Given this list of marker genes Tspan5, Myorg, Zfp275, Zbtb5, Usp38, Intu, Hif1an, Hand1, Alox8, Nr6a1, Tbkbp1, Rasgrp1, Hmga2, Leprotl1, Crb2, Trabd, Prpf38b, Smug1 (NCBI Gene Id 97982), Tgds, Rgs16, Rab8b (RAB8B, member RAS oncogene family), Cbx2, Slc2a12, Pcdh19, Cpeb2, Slc25a24, Pik3ip1, Hip1 (huntingtin interacting protein 1), Fgf11, Slc25a27, Hoxa1, Pde12, Thoc2, Nme6, Zfp583, Pcdh20, Sestd1, Ppargc1b, Gpatch3, Prkaa2, Col27a1, Ccnj, Dtx2, Mapk8, Hic2 (NCBI Gene Id 58180), Nras, Pitpnm3, Wnt9a, Begain, Agap1, Cgnl1, Lpgat1, Gpr156, Diaph2, Coil, Fign, Plekho1, Soat2, Il13, Tmod2, Liph, Fam174a, Rab11fip4, Stard13, Tgfbr3, Klk10, Gcat, Slc38a9, Scn11a, Etnk2, Ttll4, Abcb9, Acvr1c, Rictor, Igf2bp2, Adrb3, Bsn, Gatm, Ybey, Galnt1, Styk1 (serine/threonine/tyrosine kinase 1), Cflar, Atp2a2, Cpa4, Scyl3, Eef2k, Arhgap12, Zswim5, Fam135a, Gabra6, Gng5, Plpp6, Mdfi, Fndc3a, Pard6b, Igdcc4, Slc6a1, Usp47, Dna2, Kdm3a, Cemip2, Kctd21, Ddx19a, Slc16a14, G6pc2 (NCBI Gene Id 14378), Tmco1, Ccnd2, B3gnt7, Nap1l1, Cep120 (centrosomal protein 120), Fasl, Ints6l, Sowaha, Lipt2, Mycn, Cry2, Nemp1, Efhd2, Fgd6, Limd2, Masp1, Cep135, Slc66a1, Pbx1, Zfyve26, Brd3, Rgs6, Stxbp5, 2310022A10Rik, Lbr, Snn, Macf1, Mapk6, Taf9b, Usp24, Lin28b, Igdcc3, Rufy3, Plxnc1, Acat1, Igf2bp1, Faxc, Entrep2, Snx30, Ccdc71l, Eea1, Klhl6, Map3k2, Brwd1, Homer2, Plpp5, Dusp1, Dlc1, Asap1, Arid3b, Nek3, 1700017B05Rik, 5031439G07Rik, Trim41, Tmem65, Pogz, Col4a1, Pbx2, Arpp19, Lgr4, Lrig2, Egln2 (egl-9 family hypoxia-inducible factor 2), Nipal4, Cbx5, Pappa, Zc3hav1l, Stimate, Gnptab, Ehhadh, Plekha8, Stk40, Slc22a23, Gramd2b, Clasp2, Gxylt1, Adrb2, Fndc3b, Igf2bp3, Pla2g3, Has2, Cldn12, Wnt9b, Ndst2, P4ha2, Katnbl1, Pcgf3, Trim67, Edn1, Slc20a1, Tyk2, Mdm4, Slc35d2, Kctd17 (NCBI Gene Id 97993), Col4a2, Elp1, Alg11, Arid3a, Ptafr, Rfx6, Fnip2, Peg10, Utrn, Gdf6, Map4k4, Pbx3, Col3a1, Rbfox2 (NCBI Gene Id 93686), Prtg, Syt11, E2f2, Mfsd4a, Prrx1, Ccr7, Trim71, Sft2d3 (SFT2 domain containing 3), Frmd4b, Hook1, Map3k1, Tmem198b, Adamts15 (ADAM metallopeptidase with thrombospondin type 1 motif 15), Ltn1, E2f6, Arid3c, Mxd1, Tgfbr1, Onecut2, Smarcad1, Thoc1, Arhgap28, Ddx19b, Bzw1 (NCBI Gene Id 66882), E2f5, Dnaja2, Fras1, Trhde, Rbpj, Slc7a14, Mier1, Zbtb39, Col1a2, Zfp512b, Ercc6, Fnip1, D630045J12Rik, Wdfy3, Mycbp, Tmprss2, Vstm5, Cercam, Wasl, Pxdn, Grid2ip, Lrig3 (NCBI Gene Id 78922, leucine-rich repeats and immunoglobulin-like domains 3), Tmprss11f, Dnase1l2, Dtx4, Il6, Dcaf15, Sigmar1, Slf2 (NCBI Gene Id 77718), Limk2, Ints2, Kif21b (kinesin family member 21B), Dmd, Ap1s1, Tet3, Nphp3, Txlng, Bach1, Hectd2, Zfp975, Dusp22, Greb1l, Smim3, Plekhg6, Stx17, Rdx, 9930012K11Rik, Apbb3, Hdlbp, Dpp3, Cd200r1, Fignl2, Tnfaip8l3, Sall4, Kif2b, Adamts8, Cdc34, Ahctf1, Xkr8, Trim6, Fbxl12, Atl2, Thrsp, Col5a2, Ppp1r16b, Tmc7 (transmembrane channel-like gene family 7), Gga3, Pald1, Senp2, Klf8, Stx3, Skil, Cpeb1, Slc10a7, Cnot6l, Gpcpd1, Galnt2, P2rx1, Osmr, Nol4l, Ppp2r2a, Sall3, Lin28a, Casp3, Sec16b, Yod1, Gpatch2 (G patch domain containing 2), Onecut3, Dnajc1, Zfp282, Pacs2, Psd3 (NCBI Gene Id 80295), Rbms2, Map4k3, Zmat4, Rspo2, Nynrin, Ddi2, Igf1r, Bcat1, Arl5a, Plxnd1, Gas7, Adamts12, Cntrl, Arhgef15, Ngf (nerve growth factor), here is a description of the gene set: from publication Chen Y, Wang X (PMID 31504780) studied in species Mus musculus Mouse Gene Set: LET_7F_5P Genes predicted to be targets of miRBase v22 microRNA mmu_let_7f_5p in miRDB v6.0 with MirTarget v4 prediction scores > 80 (high confidence targets).